Given this list of marker genes NR5A1, NUP107, FSHR, NR0B1, NELFA, TP63, DHX37, PAX6, ZSWIM7, STAG3, VAMP7, ZFPM2, NSD2, WT1, BNC1, POLR3H, MAP3K1, SETBP1, HARS2 (NCBI Gene Id 23438), DHH, MSH4, SPIDR, CTBP1, PPP1R12A (protein phosphatase 1 regulatory subunit 12A), BMP15, CLPP, PIGG, SRY, LETM1, NOBOX, GATA4, ERAL1, WWOX, PSMC3IP, FIGLA, CPLX1, FOXL2, SOX9, MRPS22, here is a description of the gene set: Human Gene Set: HP_STREAK_OVARY A developmental disorder characterized by the progressive loss of primordial germ cells in the developing ovaries of an embryo, leading to hypoplastic ovaries composed of wavy connective tissue with occasional clumps of granulosa cells, and frequently mesonephric or hilar cells. Streak ovary studied in species Homo sapiens